Given this list of marker genes PIK3CG, IRF1, BCL10, TCF3, KDM6A, RNF31, SASH3, KMT2D, NCKAP1L, here is a description of the gene set: species: Homo sapiens An abnormal proportion of memory T cells compared to the total number of T cells in the blood. Memory T cells have previously encountered and responded to their cognate antigen and upon a repeated encounter with the antigen can mount a faster and stronger response. Human Gene Set: HP_ABNORMAL_MEMORY_T_CELL_PROPORTION Abnormal memory T cell proportion